The following is a description of a gene set: Any process that stops, prevents or reduces the frequency, rate or extent of cellular response to hypoxia. species: Homo sapiens Human Gene Set: GOBP_NEGATIVE_REGULATION_OF_CELLULAR_RESPONSE_TO_HYPOXIA, and this is the list of marker genes: COMMD1, DDAH1, ENO1, DRD2, MAP2K1, PIK3CB, NOL3, EPHA4, EGLN1 (egl-9 family hypoxia inducible factor 1), HYOU1, PINK1, TMBIM6, NFE2L2